The following is a description of a gene set: studied in species Mus musculus Any process that modulates the frequency, rate or extent of cell communication via electrical coupling. Cell communication via electrical coupling is the process that mediates signaling interactions between one cell and another cell by transfer of current between their adjacent cytoplasms via intercellular protein channels. Mouse Gene Set: GOBP_REGULATION_OF_CELL_COMMUNICATION_BY_ELECTRICAL_COUPLING, and this is the list of marker genes: Sri, Irx3, Pde4d, Camk2d, Gjd3, Ank3, Hrc, Cav1, Gja1, Gja5 (NCBI Gene Id 70659), Casq2, Cabp1